The following is a description of a gene set: species: Mus musculus Mouse Gene Set: GOBP_REGULATION_OF_LYMPHANGIOGENESIS Any process that modulates the frequency, rate or extent of lymphangiogenesis., and this is the list of marker genes: Vegfc, Vegfa, Epha2, Ccbe1, Ngp, Foxc1, Vash1